The following is a description of a gene set: from publication Chen Y, Wang X (PMID 31504780) Mouse Gene Set: MIR_7068_3P species: Mus musculus Genes predicted to be targets of miRBase v22 microRNA mmu_miR_7068_3p in miRDB v6.0 with MirTarget v4 prediction scores > 80 (high confidence targets)., and this is the list of marker genes: Kl, Nrbf2, Samd4b, Tomm20, Zfp710, Shtn1, Cstf2, Hoxa1, Hic2 (NCBI Gene Id 58180), Trappc9, Brinp2, Ccdc22, Dhfr, Wdr26, Arrdc3, Map3k9, Tbc1d22b, St6gal2 (NCBI Gene Id 240119), Nhsl2, Eva1a, Slc7a1, Tango6, Fgf5, Rap2a, Adarb2, BC107364, Hif1an, Bltp3a, Pakap, Zfp128, Kcns3, Tmem170b, Tmem161b, Chdh, Septin3, Elavl3, Szrd1, Cp (ceruloplasmin), Itsn1, Prrg3, Ifih1, Tmod2, Nudt9, Gas2l3, Recql5, Syn3, Plcd3, Pdcd1lg2, Adi1, Ppp1r3d, Col24a1 (NCBI Gene Id 71355), Nyap2, Spsb4, Notch1, Heatr6, Tbxas1, Grsf1, Zc3h4 (zinc finger CCCH-type containing 4), Wdr1, Dock11, Epha5